Given this list of marker genes CNBD2, SYT10, SERPIND1, SLC6A14, SLC48A1, OCEL1, CDR2L, GRIN3B, BCL11B, GJB3 (NCBI Gene Id 91028), MT1E, KLHDC3, FOXA2, MPC1, PHF7, KLHL11, RSPO2, GPS2, NTMT1, ARTN, PIP5K1B, ALDH1A2, KCTD17, GABRR1, ROPN1, CRABP1, YJU2B, ZNF428, CHI3L1, TSNAXIP1, MRPL1, GNL1, HES2, ST6GALNAC4, C11orf91, GSTT1, RXFP2, CHST12, DDR2, RHPN2, HID1, PSD, ATXN2, CCR4, SPSB2, CD300C, STAT5A, TSGA13, AQP4, MYOC, NDUFC1, SRA1, RRAGD, COX15, PSMD4, ZBTB16, MDFI, FETUB, YTHDF2, ACP3, FBXL15, CIITA, PA2G4, AIG1, ACADSB, SDF2L1, ICAM5, PGK2, CBLN3, CLDN3, PROZ, PWWP4, GLRA3 (glycine receptor alpha 3), CDC25C, TAF10, OTUB1, RXRG, CDC20, CASR, CDC26, ZFHX3, SYNPR, FBXW12, REL, OR5D18, PELO, FGD1, MYOZ3, SOX5, ZFYVE19, CNDP2, ACOT7, FOXD3, UNC45A, CADM3, SLC27A2, LAMTOR4, MTA3, RMDN3, FBLN5, USP17L2, VCF1, BACE1, HLX (H2.0 like homeobox), LORICRIN, P2RY2, CLIP1, SFRP1 (secreted frizzled related protein 1), FKBP2, MECR, TINAGL1, GPR37, FST, CMTM8, DDX18, ADRM1, TEX101, TESK1, EIF1AY, ARL2, NPY, PRODH2, PHC2, MYCT1, PGP, MRPL23, DNAJC1, RPS25, CDKN1A, DOLPP1, EPHA4, FBXO15, KRT1, MRPL4, FKBP10, MAU2, CAMSAP1, GRIA4, TFAP2C, CHRND, SPMIP10 (NCBI Gene Id 389320), IDO1, CUEDC2, SNX20, FSHR, HES3, AKR1D1, TRMT1, TIMM23, SCAND1, POU3F4, NRDE2, MPND, RPP21, TAF7, MRPS26, CPN1, SLAMF7, PLCB2, GJA10, TRAF3IP2, VIL1, BIRC3, SPAG4, GABRR2, ID2, NDUFB10, GADD45A, HSPB2, FBN1, SYTL1, RNF126, PIM1, PFDN5, DGKA, PDPN, AIMP2, WDTC1, NTNG1, PDCD6, HPD, RPL39, RGS1, ASF1A, DQX1, CARD14, SCML4, CFAP95, RECQL4, GNAI2, DHDDS, COQ8B, GDAP1L1, ABCF2, TNIP1, INCA1, CAP1, NT5C3B, UBC, HLA-E, here is a description of the gene set: Human Gene Set: GSE17721_CTRL_VS_CPG_0.5H_BMDC_DN mouse primary BMDCs were stimulated with tlr ligands and gene expression changes were profiled on Affymetrix arrays from publication Amit I, Garber M, Chevrier N, Leite AP, Donner Y, Eisenhaure T, Guttman M, Grenier JK, Li W, Zuk O, Schubert LA, Birditt B, Shay T, Goren A, Zhang X, Smith Z, Deering R, McDonald RC, Cabili M, Bernstein BE, Rinn JL, Meissner A, Root DE, Hacohen N, Regev A (PMID 19729616) studied in species Homo sapiens Genes down-regulated in comparison of control dendritic cells (DC) at 0 h versus those stimulated with CpG DNA (TLR9 agonist) at 0.5 h.